The following is a description of a gene set: species: Mus musculus from publication Chen Y, Wang X (PMID 31504780) Mouse Gene Set: MIR_128_1_5P_MIR_128_2_5P Genes predicted to be targets of miRBase v22 microRNA mmu_miR_128_1_5p, mmu_miR_128_2_5p in miRDB v6.0 with MirTarget v4 prediction scores > 80 (high confidence targets)., and this is the list of marker genes: Naa11, Krtap10-31, Cbfa2t3 (NCBI Gene Id 320906), Ces3b, Ikzf4, Tgfb3, Iqsec2, Slc39a1